The following is a description of a gene set: studied in species Homo sapiens Human Gene Set: HP_EYELID_APRAXIA Eyelid apraxia, and this is the list of marker genes: MAPT, PANK2, ATP13A2, SYNJ1, PLA2G6